The following is a description of a gene set: Immune cell-specific expression is one indication of the importance of a gene's role in the immune response. In order to identify such patterns, we set out to broadly profile gene expression in a variety of immune cells. Genes up-regulated in comparison of naive CD4 T cells versus day 0 monocytes. Human Gene Set: GSE22886_NAIVE_CD4_TCELL_VS_MONOCYTE_UP studied in species Homo sapiens from publication Abbas AR, Baldwin D, Ma Y, Ouyang W, Gurney A, Martin F, Fong S, van Lookeren Campagne M, Godowski P, Williams PM, Chan AC, Clark HF (PMID 15789058), and this is the list of marker genes: CDC25B, SH3YL1, RNASEH1, LBH, GAMT, EPHX2, CD69, LIME1, UNG, LINC00342, MAL, LTBP4, LRRN3, TRAT1, ADPRM, TPD52, TRAC, CLEC2D, TXK, HAUS3, P2RY10 (NCBI Gene Id 27334), FAM169A, SKAP1, ZAP70, ZNF394, SLC38A1, CBLB (NCBI Gene Id 868), LCK (NCBI Gene Id 95387), ABCA5, NELL2, TESPA1, TMEM204, SH2D1A, CDR2, ETS1, ITK, NXT1, BCL2, SMPD1, GYPC, PKIA, CLK1, AQP3, GZMA, WDR76, RORA, TRAV8-3, MCF2L, SLC25A38, PASK (NCBI Gene Id 26144), OXCT1, UNC119B, HMOX2, ICOS, HKDC1, SNPH, ENO2, LTBP3, DENND2D, HSD17B8, DPP4, ZBTB20, PLEKHA1, ZNHIT6, PTPN4, CD3E, ZNF76, PTPRCAP, ZNF529, TRIB2, TLE2, SESN1, LDLRAP1, GZMM, DGKA, TBC1D4, TRMT11, TRBC1, ALDOC, PJA1, NIPAL3, TRAF5, AKTIP, PDCD4-AS1, ADNP2, HSPB1, AMMECR1, NCK2, AP3M2, PIK3R1, ZNF14, SETMAR, BAG2, APPL2, BACH2, ITM2A (NCBI Gene Id 9452), SEL1L3, FLT3LG, SYNE2 (spectrin repeat containing nuclear envelope protein 2), RAB33A, CCND2, PRMT1, GOLGA8B, PBXIP1, PRKCA, CHMP7, ZNF224, MAGED1, UBASH3A, GPR171, MYLIP, NR3C2, INSL3, RETREG1, TP53TG1, GSDMB, GPRASP1, EEIG1, PVRIG, STMN3, TOX, MGAT4A, MLLT3, CD27, CD40LG (NCBI Gene Id 959), IPP, KIF5C, BNIP3, MPRIP, ZNF331, HSF2, NOSIP, PDE4D, PILRB, SIDT1, PLEKHB1, CD96, SPOCK2, INPP4B, PLCG1, FCMR, ZNF136, LPIN1, CHD7, TSR2, BEX3, PRR5, LEF1, TMEM14A, IL32, PRMT2, CD5, NUCB2, ZNF551, ZNF506, CD6, NAP1L3, SLC16A10, ZBTB25, LY9, TENT5C, KIF21B, ABLIM1, TNIK, LRBA, KLHL3, SMYD3, GNB5, CD28, LIG1, FBLN5, CD7, SIRPG, ITPR3, PRKCH, DNAJC9 (DnaJ heat shock protein family (Hsp40) member C9), DEFA4, GPR18, ITM2C, BCL11B, CD247, CAMK4, ITGA6, CLUHP3, ECHDC2, FBXW4, TNRC6B, CD3D, CD3G, DOCK9, QTRT1, TMEM30B, ADGRL1, LRIG1, S1PR1, BIN1, PRKCQ